Given this list of marker genes IGHV3-48, GNG5, VAV3, IGKV1-39, NFKB2, IGKV5-2, AHCYL1 (NCBI Gene Id 29039), DVL2, BAIAP2, IGLV3-19, GNG13, PRKACG, WIPF2, IGHV3-13, GNB2, IGHV4-39, ARPC2 (NCBI Gene Id 220721), HCK, ACTB (actin beta), VAV2, HMOX1, PTK2, IGKV2D-30, ENTPD5, RELA, ABL1, CYSLTR2, DPEP1, FURIN, IGHG3 (NCBI Gene Id 3502), IGLV3-27, P2RX7, NLRP3, YES1, IGLC2, IGLV, IGKV2D-28, DPEP2, CALM1, GNAI3, VAV1 (vav guanine nucleotide exchange factor 1), IGHV7-81, IGHV4-34, CYBA, IGHV1-46, CD163, HSP90AB1, MAPK14, PRKAR1B, ARPC1A, ITPR1, BTK, WASF1, IGHV3-53, IGLV7-43 (NCBI Gene Id 28776), GGT5, C3, MYH9, IGLC3, MYO9B, CYFIP2, C3AR1, IGKV1-5, TXN, IGHV3-7, NCKIPSD, GNG8, WIPF3, WIPF1, IGLV1-47 (NCBI Gene Id 28822), SYK, DVL1, GNAZ, IGLV8-61, GNAT3, IGLV2-8, FCGR2A, IGLV2-11, ADCY2, IGLV1-40 (NCBI Gene Id 28825), RHBDF2, IGHG2, WASF3 (WASP family member 3), WASL, IGKV1-33, MYO5A (myosin VA), CASP1, IGLV1-51, MYH2, ARPC4, IGKV2D-40, GNAI2, GNG11, ELMO2, hly, IGLV4-60, CYFIP1, IGLV3-12, ADCY7, ENTPD1, IGLV7-46, PLCG1, PRKACB, IGHV3-11, WNT5A, GSDMD, IGKV1-12, IGHV, IGKV1D-33, NOX1, RAC1, ADCY1, SRC, PLK2, DOCK1, IGLV10-54, GNG10, IL1A, CD247, NOXA1, IGLC1, IGLV2-14, PYCARD, GNB1, ABI2, IGHV1-69, MAPK8, IGKV1D-16, IL6, ARPC3 (actin related protein 2/3 complex subunit 3), GNAI1, ADCY6, IGHV1-2, IL18, CREB1, ADCY8, NT5E, NFKB1, CDC42, IGHV3-30, GRB2, ITPR3, IL1B, MAPK1, IGLV5-37, IGKV3-11, GGT1, GNG3, IGKV1D-12, SUGT1, IGKV3-15, ADCY4, IGLV3-22, CTSG, GNB3, IGKV2-28, IGKV2-30, PLCG2, GNB5, GNAS, PRKACA, IGLV1-36, IGLV3-25, PRKAR2A, FCGR1A, IGHV3-33, GNB4, ITPR2, IGLV5-45, P2RX4, IGLV4-3, ADCY3 (NCBI Gene Id 9608), ADORA2B, IGHV3-9, GNG4, IGHG1, CYSLTR1, NOXO1 (NADPH oxidase organizer 1), IGKV1D-39, IGKC, ELMO1, CRK, WAS, PRKAR1A, IGKV4-1, MYO10, CD3G, IGHG4, PRKX, IGKV1-16, GNGT2, IGHV4-59, MYO1C, IGLV6-57, PSTPIP1, LYN, FGR, JUN, MAPK3, IGLV1-44, FYN, IGKV1-17, TXNIP, IGLV2-18, ACTR3, IL10, ARPC5, ARPC1B, APP, FZD7, ADCY9, MEFV, LPG1G2, DVL3, IGLV3-1, BRK1, IGLV2-33, WASF2, GNG12, GNGT1, ADCY5, IGKV3D-20, GNG7, ACTG1, IGLV3-21, IGLV3-16, GNG2, NCKAP1L, IGLV11-55, IGHV3-23, NCK1, IGLV2-23, PRKAR2B, IGLV4-69, ABI1, ADAM17, IGHV2-70, FCGR3A, ACTR2, IGKV3-20, IGHV2-5, IGLC6, IGKV2-29, IGLC7, NCKAP1, here is a description of the gene set: studied in species Homo sapiens Intracellular parasites of the genus Leishmania constitute the etiologic agent of a disease complex called Leishmaniasis. Leishmania parasites alternate between two distinct developmental stages: the insect-adapted, flagellated, extracellular “promastigote” and the mammal-adapted, non flagellated, intracellular “amastigote” form, where the later resides within phagolysosomal vesicles of the phagocytic cell. Paradoxically, the macrophage, which is the main host cell where the parasite replicates and grows, is at the same time the main cell responsible for its elimination.<br><br>The uptake of Leishmania promastigotes by host cells is a receptor mediated process that initiates phagocytosis. Some parasites differentiate and survive within the macrophage phagolysosomes; others are killed by the acidic and higher temperature environment. In the end, it is the balance between the host and parasitic factors that control the activation/deactivation of macrophages that determines the fate of the parasites as well as the infection outcome.<br><br>The pathways curated here summarize the major steps of parasite internalization by the macrophage, the defence mechanisms that are turned on and the mechanisms of evasion of the parasite to counteract them.<br><br> Reactome Pathway: Leishmania infection part of: Parasitic Infection Pathways